The following is a description of a gene set: Human Gene Set: MODULE_60 Heart genes. studied in species Homo sapiens, and this is the list of marker genes: ITGB7, ITGA10, ICAM3, DNM2, NME3 (NME/NM23 nucleoside diphosphate kinase 3), CLDN9, DHRS2, FHIT (NCBI Gene Id 2385), NECAB3, ITPR2 (inositol 1,4,5-trisphosphate receptor type 2), PPP1R15A, PDGFRA, IVD, RNF167, GTPBP1 (NCBI Gene Id 9567), GJA4, TGFB1, RPS26, IGFBP4, PPP2R5D, SVIL, ALDOB, SLC29A1, CCN5, ECE1, BCAM, DDT, DKK4, DPYSL4, RNASE1, ADIRF, DLEC1, STAB1, ACTC1, ST6GALNAC4, COL6A1, PKMYT1, ARFRP1, GALR3, ABCA1, MAN2C1, DEFA3, LGMN, PDE2A, ADGRE5, TAFAZZIN, ECHS1, TCF7, TFF3, AGPAT2, TUB, IGF1, MCRS1, CES1, CKM, APOC4, SMAGP, NRTN, MAPRE2, TNFRSF13B, KYAT1, HYI, TNNT3, ADH1A, PCOLCE, CD14, FAM107A, CCND1, PPP1R1A, PKN1, KDM5C, NR4A1, IFFO1, HLA-DMA, HCLS1, MYH11, CORO1A, BRD4, BCKDK, TFAP2B, AQP1, MICAL2, PLAU, SNCG, AGT, SPIB, KCNMB1, RAC2, TOB2, COL2A1, PDLIM5, TBX5, CTF1, QSOX1, TACC2, LSP1, ISG15, PSG7, SLC2A1, C1QB, APOD, TGFBR2, KCNJ4, LGALS9, AMT, GPA33 (glycoprotein A33), EPOR, CD8A, CACNB1, IGHG3 (NCBI Gene Id 3502), TTLL12, AQP7, PLAAT4, TNFRSF1B, STOML1, RBPMS, KCNH2, PCBD1, PLXND1, SIPA1, CFP, CST7 (cystatin F), TAF1, H2BC21, EEF1A2, HLA-DQB1, TBX1, ZYX, APRT, FGR (NCBI Gene Id 2268), MAP2K3, BLVRB, ROR2, MAPK8IP3, GMPR, AKR1C1, NHERF1, ATP6V0A1, MAOB, KCNA5, MEF2D, TGM2, BMERB1, MAPKAPK3, AQP3, TNNC1, LAMB2, ACKR2, NKG7, NFKBIL1, TGFBI, COX6A2, TRANK1, RAMP1, FCER1G, HMOX1, EIF4EBP1, ALAS1, SCN1B (NCBI Gene Id 6324), WT1-AS, NDUFB7, FPR2, LLGL2, DEPP1, ACAA1, EMP3, VEGFA, CLEC3B, IGF2, TBX19, TM7SF2, ICMT, ABLIM3, HSD17B1, ELAC2, HAGH, INHBC, POLD2, CHRNB1, PLEC, PRELID3A, CCL2, GOT1, FSTL3, PTP4A3, SCN4A, ITGA7, SERPINH1, MPG, EDC4, CD151, CDKN1A, SEMA3F, EFNA2, RBMS3, UBXN1, CARD10, NR1D1, CHPF, FKBP8, CELSR3, TPSAB1, KLHDC3, PPP6R2, ENTREP1, EPAS1, NR5A1, PTPRCAP, ACOT2, OGG1, PSMB10, ALDH4A1, TYMP, RHOB, FDXR (ferredoxin reductase), ELN, ASCC2 (NCBI Gene Id 84164), GBF1, RGL2, RAMP2, MFAP4, HSPB2, PRF1, DENND2B, SBNO2, MAN2B1, ZIC2, PLAAT3, LTBR, ETFB (electron transfer flavoprotein subunit beta), MTHFR, BCKDHA, NTNG1, CYP2A6, S100A11, HYAL1, ENG, CYB5R1, DHRS3, VTN, SPTB, GAA, EPHX1, CD79A, LPL, CD37, IFI27, RGS3, RRAD, GYG1, ITGB4, PLEKHO2, LST1, FBLN2, TYR, CDK18, TXN2, PCBP4, ECI1, PTGDS, NAPA (NSF attachment protein alpha), TLE2, NEURL1, MCM2, IER3, CFAP410, GAGE12F, PDXK, DOK1, TRPM2, CD34, MYOG, PARD6A, HBEGF, S100A4, ST3GAL4, SRPX, DLK1, TAP1, PTGIS, LRRC32, PKD1, POLR2J (NCBI Gene Id 5439), APOE, PPP1R12B, SLC6A8, CDA, TST, HTR4, POMZP3, HPGD, GRN, HSPG2, PRG2 (NCBI Gene Id 87065), IL32, ACR, SCAMP5, KCND3, G0S2, LARGE1, TOM1, CRYBA4, GDPD5, ESRRA, FN1, CCL21, AANAT, PBX1, NOTCH3, APOC1, RARRES2, CDH16, TNXB, PIK3C2B (phosphatidylinositol-4-phosphate 3-kinase catalytic subunit type 2 beta), GSTT1, DELE1, ZKSCAN7, LAIR1, CD8B, GAS1, CSRP3, CLN3, M6PR, GPNMB, POLA2, SLC4A3 (NCBI Gene Id 7858), COL1A2 (NCBI Gene Id 1278), CD3E, LCK, PGAM2, CDH2, MYOM1, SRPK3, IGFBP2, SLIT2, LY6G6C, AAK1, GATD3, TIMP3, BDH1, TNFRSF14, RHOD, IGHM, VWF, MYL9, FGFR1, CFD, FXYD1, VSIG4, CDH5, TRIB1, TSPAN7, CDC42EP1, TJP1, CRABP1, ACKR1, GSTM1, DPP6, NNMT, CD52, SOD3, GNG7, CCND2, TRAPPC6A, VAMP5, FHL2, TP53I11, PLIN1 (perilipin 1), CRYAB, GPSM3, CCR1, SMARCD3, HTR6, CRYM, ZKSCAN3, CDK5R1, PER1, CCL5, PDK2, LDAF1, WAS, ARHGEF16, PLK3, COX7A1, COL15A1, FEV, IGFBP6, WFS1, SORBS2, CREBZF, JADE2, S1PR4, SMTN, THRA, PDGFRB, TIMM17B, TRIM16, CRIP1, ITGB5, CNKSR1, COL6A2, FZR1, CA4, HSF1, JAK3, C2, MB (NCBI Gene Id 4151), MYL2, IFI35, GPX3, CITED2, PNRC1, DDIT4, DMTN, RHBDL1, FEZ1, TNFAIP2, LTB, FCGRT, NECTIN2, TPM2, CLDN5, UBE2L6